Given this list of marker genes BMP2, ATP1A1, REST, DKK3 (dickkopf WNT signaling pathway inhibitor 3), BMP5, here is a description of the gene set: studied in species Homo sapiens Any process that stops, prevents, or reduces the frequency, rate or extent of the chemical reactions and pathways involving glucocorticoids. Human Gene Set: GOBP_NEGATIVE_REGULATION_OF_GLUCOCORTICOID_METABOLIC_PROCESS